The following is a description of a gene set: Mouse Gene Set: REACTOME_ACROSOME_REACTION_AND_SPERM_OOCYTE_MEMBRANE_BINDING species: Mus musculus Acrosome Reaction and Sperm:Oocyte Membrane Binding, and this is the list of marker genes: Cd9, Acr, Izumo1, Izumo4, Izumo3, Izumo2